Given this list of marker genes CCDC6, SPTAN1, PHYH, NRBP2, LLGL2, PRSS23, DUSP1, GRB10, SLC38A4, PER1, PMP22, NUPR1, TP53INP2, KLF2, DHRS7, PSTPIP1, CD151, CHFR, GRK5, SPTBN1, COL5A1, AKAP12, COQ9, SRI, STK10, TSPAN4, TNXB, LPL, IL6ST, MAN2B1, EBF3, CRLF1, TMEM45A, RFLNB, ENO3, RBMS2, SNX10, COL4A2, FOXP1, SLC39A3, NMT1, RNASE4, SMAD6, FZD2, RAB11FIP5, ELN, ARL2BP, CALML4, LAMB2, MSLN, ID3, SLPI, SEMA3C, FHL1, DHRS3, S100A13, MFAP5, SH3D19, FKBP10, PFKP, TRIM47, GSN, SEC14L1, RNPEPL1, H2BC4, AMOTL2, DGCR2, VAMP5, SLC1A5, AQP1, ADM, ATP11A, TUBB2A, FBN1, IFI35, LASP1, SEC61B, CTDSP2, COL1A1, EMP2, PCOLCE, SLC4A3, NDRG4, PLTP, PNP, CD9, COPZ2, ABLIM1, SOCS3, APP, GUK1, ALDH1A1, ITGB5, ISG15, SHROOM3, GAS1, TOB1, LDAF1, CRTAP, IFI30, FSTL1, DDR1, KAZALD1, ANXA8L1 (annexin A8 like 1), GSTM5, VDR, HOXA2, EPHX1, NOTCH1, ATF3, PEF1 (NCBI Gene Id 553115), RECK, PLAC8, CCN2, SARAF, PAPSS2, LGALS9, DIPK2A, CDKL2, ST3GAL5, CCDC80, NTPCR, ASAH1, INPP5A, TM2D2, CES2, TCF7L1, WWP2, COL5A2, COL4A5, TIMP3, MAP1LC3B, COL1A2, CITED2, SLCO3A1, FOS, SAMHD1, SESN1, SLC29A1, BMP8A, JUP, here is a description of the gene set: Mutational activation of ras genes is required for the onset and maintenance of different malignancies. Here we show, using a combination of molecular physiology, nutritional perturbations and transcriptional profiling, that full penetrance of phenotypes related to oncogenic Ras activation, including the shift of carbon metabolism towards fermentation and upregulation of key cell cycle regulators, is dependent upon glucose availability. These responses are induced by Ras activation, being specifically reverted by downregulation of the Ras pathway obtained through the expression of a dominant-negative Ras-specific guanine nucleotide exchange protein. Our data allow to link directly to ras activation the alteration in energy metabolism of cancer cells, their fragility towards glucose shortage and ensuing apoptotic death. species: Mus musculus Human Gene Set: CHIARADONNA_NEOPLASTIC_TRANSFORMATION_KRAS_DN Genes down-regulated in transformed NIH3T3 cells (fibroblasts transformed by activated KRAS) vs normal cells. from publication Chiaradonna F, Sacco E, Manzoni R, Giorgio M, Vanoni M, Alberghina L (PMID 16607279)